The following is a description of a gene set: Progression through the phases of the meiotic cell cycle, in which canonically a cell replicates to produce four offspring with half the chromosomal content of the progenitor cell via two nuclear divisions. Human Gene Set: GOBP_MEIOTIC_CELL_CYCLE studied in species Homo sapiens, and this is the list of marker genes: HSF2BP, SPO11, NPM2, ANAPC11, H2AX, KASH5, NSUN2, TEX15, KCTD19, OOEP, LFNG, CENPC, DDX4, CDC23, STK35, GOLGA2, TUBGCP2, TOP3A, HORMAD2, TOP2B, ANAPC4, GPR3, PSMD13, KNL1, PIWIL3, SLX4, FBXO43, UBE2B, SPIN1, SGO2, YTHDC2, REC114, MSH4, DMRTC2, ANAPC16, FOXJ3, TUBGCP3, SYCE1L, PRR19, AGO4, TEX12, RNF212B, NUF2, WBP2NL, ZCWPW1, SPATA22, SYCP1, RAB24, ANKLE1, ANAPC15 (NCBI Gene Id 25906), ANAPC5, PLD6, ING2, CALR, SMC2, DCAF13, SYCP2, ACTR3, WASHC5, BTBD18, STAG3, FAM9C, HUS1B, TDRKH, SHCBP1L, ZNF541, CDC25C, DNMT3L, NCAPD2, KLHDC3, NPR2, ZWINT, MLH3, MOS, FOXJ2, MAEL, MUS81, ASPM, CCNE1, OVOL1, ZNF318 (NCBI Gene Id 24149), FANCD2, PLK1, EME2, SKA2, RAD51C, MEIKIN, SGO1, NPPC, RBM7, DMRT1, WEE2 (NCBI Gene Id 494551), DMC1, CCNB1IP1, TUBG2, FIGNL1, TUBGCP4, PDE3A, FANCM, RAD54B, ACTR2, AURKA, FZR1, NDC80, SUN1 (NCBI Gene Id 80226), BRCA2, SPIRE2, RAD1, RNF212, MYH9, PIWIL4, ANAPC7 (anaphase promoting complex subunit 7), REDIC1, SKA3, ZSCAN21, TDRD1, SYCE1, EXD1, PSMC3IP, CENPX, TERF1, RAD21L1, CCNE2, CATSPERZ, M1AP, EREG, ZW10, CDC26, YTHDF2, SLC2A8, MEI1, MSX2, BUB3, SKA1, HSPA2, SYCE2, FANCA (FA complementation group A), IHO1, FKBP6 (NCBI Gene Id 8468), USP17L2, FAM9B, DDB1, TAF1L, TUBG1, RSPH1, C9orf78, MSH6 (mutS homolog 6), RAD51, EHMT2, SMC3, EME1, NCAPH, NDC1, DAZL, SLC25A31, MNS1, ASZ1, UBR2, MAJIN, C14orf39, LIF (NCBI Gene Id 3976), REC8, MAPK15, PPP2CA, CDC16, PPP2R1A, DUSP13B, MCMDC2, SLC26A8, SYCE3, CNTD1, EXO1, ANKRD31, CDC20, PIWIL2, SIRT2, MASTL, ORC4, HFM1, MSX1, ERCC4, NCAPD3, MLH1, AURKC, RAD51AP1, TOP2A, KIF18A, PRDM9, TERB2, EDNRA, RAD50, RPA1 (replication protein A1, NCBI Gene Id 6117), HORMAD1, ANAPC2, RPS6KA2, CKS2, SHOC1, NCAPH2, EDN1, TEX19, TERB1, BRME1, MYBL1, RAD21, TEX11, RBM46, MEIOC, CCNB2, MEIOSIN, MSH5, PDIK1L, RAD51B, TRIM75, UTP14C (NCBI Gene Id 9724), HUS1, STRA8, CCNB3, ANAPC13, MARF1, INSR, WNT5A, ATM, CDC25A, PTEN, RAD54L, MEIOB, RMI1, RAD51D, RPL10L, FAM9A, H1-8, CDC27, NANOS2 (nanos C2HC-type zinc finger 2), BRDT, WNT4, SMC1A (NCBI Gene Id 8243), TUBGCP5, BAG6, ESPL1, INCENP, HSF1 (NCBI Gene Id 642255), PTTG3P, PSMA8, TUBB8, RBBP8, FMN2, ZFP42, PLCB1, CHFR, CYP26B1, BOLL, STAG2, CENPS, SMC4, SMC1B, TRIP13, SEPTIN1, TEX14, PTTG2, SUN2, MEI4, BRIP1, MRE11, BCL2L11, TDRD12, MND1, XRCC2, MOV10L1, SIRT7, C1orf146, NBN, DUSP1, ANAPC1, CDC25B, ANAPC10, SYCP3, NUMA1, TOP6BL, OSGIN2, TUBGCP6, HSF5, SPIRE1, CDK2, SPDYA, NEK2, LSM14B, TDRD9, UBB, CCNA1, TTK, PTTG1, PKMYT1, ATRX, TESMIN, P3H4, METTL3 (NCBI Gene Id 95719), PIWIL1, FBXO5